The following is a description of a gene set: species: Mus musculus Mouse Gene Set: chrXA5, and this is the list of marker genes: Gm14622, Mospd1, Kis2, Gm14593, Aifm1, AW822252 (NCBI Gene Id 331578), Gm7840, Hprt1, Gm14612, Gm7958, Gm7803 (predicted gene 7803), Gm7212, Gm14601, Gm16428, Gm14592, Usp26, Or11n2, Or1aa2, Mir503hg, Mir20b, Gm7950, Gm14639, Gm14620, Ct55, Gpc4, Gm14696, Gm14599, Zfp36l3, Mir450b, Gm14598, Arhgap36, Or5o1, Gm14648, 1700013H16Rik, Mir92-2, Mir322, Igsf1, Sash3, Gm14644, Xpnpep2, Gm22550, Rtl8c, Gm24038, Gm16431, Gm14600, Gm14623, Slxl1 (NCBI Gene Id 75140), Elf4, Gm7916, Zfp280c, Mir717, Frmd7, Magea14, Gm14719, Mir363, Fsip2l, Mir19b-2, Or11q2, Rap2c, Gm6025, Mir6384, Pabir2, Gm22539, Gm14586, Rtl8b, Gm14584, Atf1-ps, Ccdc160, Rps2-ps13, Pou5f1-rs8 (NCBI Gene Id 624936), Bcorl1, Gm15482, Gm16404, Apln, Gm7219, A630012P03Rik, 4933416I08Rik, Enox2, Pabir3, Ocrl, Gm14585, Xlr, Mir351, Gm14607, Gm14589, Utp14a, Plac1, Mbnl3, 3830403N18Rik (NCBI Gene Id 70691), Gm6664, Gm5387, Mir542, Gm7927, Gm14595, Gm14594, Mir106a, Gm7974, Hs6st2, Gm7851, Gm14625, Firre, Mir503, Gm53064, Gm6591, Mir18b, Gm16405, Gm15033, Gm14596, Gm14590, Zdhhc9, Mir450-2, Gm14582, Slc25a14, Gm5388, Stk26, Rtl8a, Gpr119, Rab33a, Phf6, Rbmx2, Gm16430, Smarca1, Btf3-ps10, Gpc3, Mir450-1, Gm6660, Or5bh3, Gm14621, Etd